Given this list of marker genes Klk1, Ctsd, Mmp25, Klk1b3, Capn12, Agrn, Capn10, Actc1, Itga8, Itga10, Tgfb2, Emilin1, Mmp15, Col7a1, Col28a1, Col26a1, Jam2, Sgca, Sdc3, Dtna, Icam5, Tpsb2, Tgfb1 (transforming growth factor, beta 1), Col15a1, Gdf5, Col25a1, Col1a1, Itgb4, Drp2, Utrn, Megf6, Prss1l, Col2a1, Snta1 (syntrophin, acidic 1), Pecam1, Col13a1, Fgg, Mfap2, Col14a1 (collagen, type XIV, alpha 1), Nid2, Prss3, Klk1b26, Elane, Ctsl, Col6a6, Itgax, Col20a1, Vtn, Scube1, Sh3pxd2a, Madcam1 (mucosal vascular addressin cell adhesion molecule 1), Try5, Col8a1, Icam2, Pcolce2, Ctsg, Actg2, Vwf, Capn13, Tll2, Itga7, Klk1b5, Capn3, Thbs1, Mmp10, Mmp16 (NCBI Gene Id 56518, matrix metallopeptidase 16), Mmp2, Actg1, Col4a4, Capn1, Sdc2, P4ha1, Emilin2, Col16a1, Capn9, Col5a3, Col9a2, Sntb2, Itgad (NCBI Gene Id 381924), Adam10, Adamts3, Itgb7, Col4a3, Itgb8, Itga1, Klkb1, Bmp1, Mmp1a (matrix metallopeptidase 1a (interstitial collagenase)), Mmp13, Adamts4, Col17a1, Sgce (sarcoglycan, epsilon), Capn5, Tgfb3, Htra1, Col22a1, Tnn, Col11a1, Ltbp4, Itgae, Sparc, Prss2, Ltbp2, Capn2, Itga6, Itgam, Matn1, Itga5, Itga2b, Colgalt2, Itga4, Capns2, Ibsp, Loxl1, Acta1, Emilin3, Bgn, Ctss, Itgal, Bmp2, Sdc1, Mmp24, Ddr1, Col19a1, Icam1, Klk1b16, Prss3l, BC051665, Ddr2, Itga3, Klk1b27, Capn7, Matn3, Dag1, Fbn1, Pcolce, Matn4, Spock3, Dmd, Mmp3, Cast, Comp, Loxl2, A2m, Bmp10, Furin, Klk7, Col3a1, Acan, Actb, Ltbp1, Itgb3, Klk1b21, Nid1, Efemp2, Timp2, Try4, Klk1b22 (NCBI Gene Id 13646), Capn11, Lum, Col4a6, Cd44, P4ha2, Plg, Mfap5, Mmp9, Eln (NCBI Gene Id 319426), Lox, Col4a5, Sgcz, Col23a1, Prss1, P4ha3, Col9a1, Bsg, Mmp14, Tll1, Lama4, Dmp1, Itgb2, Icam4, Serpinh1, Col11a2, Col9a3, P4hb, Fbln2, Adam8, Itga2, Bcan, Tmprss6, Sgcd, Klk1b8, Fbn2, Fgb, Fgf2, Dcn, Sntg2, Ltbp3, Ctsk, Phykpl, Ctrb1, Col8a2, Loxl4, Timp1, Col6a5, Mmp11, Tnxb, Capn15, Capns1, Dtnb, Vcam1, Col6a3, Hapln1, Sntb1, Bmp7, Acta2, Mmp17, Spp1, Adam12, F11r, Adam15, Sgcb, Scube3, Itgb1, Capn6, Tnc, Klk1b4, Col6a2, Itga11, Col12a1, Optc (NCBI Gene Id 269120), Itgb6, Sspn, Ctsb, Klk1b24, Jam3, Itgav, Fbln5, Adam19, Adamts14, Col6a1, Col5a1, Cma1, Col1a2, Fga, Pxdn, Plod1, Col4a1, P3h2, P3h3, Col5a2, Dspp, Klk1b1, Itga9, Try10, Vcan, Plod3, Tnr, Colgalt1, Col10a1 (collagen, type X, alpha 1), Serpine1, Sgcg, Col18a1, Fn1, Adamts5, App, Adamts2, Bmp4, Mmp7, Capn8, Klk1b11, Col4a2, Loxl3, Mmp19, Mmp8, Klk1b9, Plod2, Ceacam1, Mmp20, Mmp12, Mfap4 (microfibrillar-associated protein 4), Sdc4, Cd47, here is a description of the gene set: Extracellular matrix organization Mouse Gene Set: REACTOME_EXTRACELLULAR_MATRIX_ORGANIZATION species: Mus musculus